The following is a description of a gene set: part of: Diseases associated with surfactant metabolism studied in species Homo sapiens One function of the pulmonary collectins, surfactant proteins A1, A2, A3 and D (SFTPAs, D), is that they influence surfactant homeostasis, contributing to the physical structures of lipids in the alveoli and to the regulation of surfactant function and metabolism. They are directly secreted from alveolar type II cells into the airway to function as part of the surfactant. The mechanism of secretion is unknown. Mutations in SFTPA2 disrupt protein structure and the defective protein is retained in the ER membrane causing idiopathic pulmonary fibrosis (IPF; MIM:178500). IPF is one of a family of idiopathic pneumonias sharing clinical features of shortness of breath, formation of scar tissue and varying degrees of inflammation and/or fibrosis on lung biopsy. IPF is typically progressive, leading to death from respiratory failure within 2-5 years of diagnosis in the majority of instances (Meltzer & Noble 2008, Noble & Barkauskas 2012). Reactome Pathway: Defective SFTPA2 causes IPF, and this is the list of marker genes: SFTPA2